The following is a description of a gene set: Mouse Gene Set: GOBP_INTESTINAL_EPITHELIAL_CELL_DEVELOPMENT studied in species Mus musculus The process whose specific outcome is the progression of a columnar/cuboidal epithelial cell of the intestine over time, from its formation to the mature structure., and this is the list of marker genes: Src, Mir7-2, Mir203, Nkx3-2, Mir7-1, Dicer1, Tyms, Yap1, Hif1a, Hoxa5, Cdh1, Klf5, Cdkn1a, Yipf6, C1galt1, Spdef, Tlr9, Prdm1, Tmigd1, Tigar, Gsdmc2, Il6st, Fzd5